Given this list of marker genes CHST3 (carbohydrate sulfotransferase 3), IFT140, HS2ST1, DYM, COL2A1, ADAMTSL2, SMARCAL1, TRAPPC2, CDC6, COL11A2, CANT1, COG1, COMP (NCBI Gene Id 5659), GLB1, EXTL3, KIF22, MATN3, PLOD3, PIK3C2A, here is a description of the gene set: Absence or underdevelopment of the proximal epiphysis of the femur. studied in species Homo sapiens Aplasia/Hypoplasia of the capital femoral epiphysis Human Gene Set: HP_APLASIA_HYPOPLASIA_OF_THE_CAPITAL_FEMORAL_EPIPHYSIS